Given this list of marker genes Rhbg, Rhcg, Aqp1, Aqp6, Rhag, here is a description of the gene set: species: Mus musculus Mouse Gene Set: GOMF_CARBON_DIOXIDE_TRANSMEMBRANE_TRANSPORTER_ACTIVITY Enables the transfer of carbon dioxide (CO2) from one side of a membrane to the other.